Given this list of marker genes Fmr1, Cdyl2, Anp32b, Sf3b4, Pcbp2, Ednrb, Tspan14, Cavin1, Ybx1 (Y box protein 1), Ier2, Junb, Rpl39, Rplp0, Eif3f, Ube2q1, Rnd1, Cdc37, Prdx1, Sdhc, Rpsa, Pkm, Dcn, Klf13, Eed, Mef2c, Eif5a, Set, Rps9, Rps16, Ehd4, Rpl14, Kcnb1, Fnip1, Per2, Dnm3, Cpa1, Selenok, Zkscan1, Cdk13, 1110038F14Rik, Zg16, Cd63, Rpl8, Anxa3, Senp6, Rpl6, Zfp955b, Rps10, Ppp1r9b, Morf4l1, Jund, Rpl4, Rdx, Cela2a, Drap1, Rps17, Psmc1, Nsun4, Cetn2, Smim14, Smagp, Dlgap4 (NCBI Gene Id 98882), Pebp1, Ifitm2, Rbm26, Bri3, Arf4, Rpl36, Fus (NCBI Gene Id 338527), Hlf, Bsg, Slc30a9, Egr1, Tbkbp1, Rapgef4, Csf1r, Nfib, Rps3, Lmcd1, Ttc28, Myct1 (NCBI Gene Id 68632, myc target 1), Tnfrsf1a, Pmm2, 2200002D01Rik, Cebpg, Rnaset2b, Tff2, Taldo1, Sub1, Cic, Csf1, Nop53, Plekho1, Klf7, Tle5, Dusp1, Ext2, Sod1, Selenow, Map1lc3a (microtubule-associated protein 1 light chain 3 alpha), Ginm1, Ptms, Abi1, Rps3a1, Arpc2, Tsc22d1, Pi15, Sfswap, Rhoj, Psmd7, Cox7c, Rpl10a (ribosomal protein L10A), Ppp4c, Zfand5, Adrm1, Selenom, Taok2, Pmp22, Hspb7, Vcf1, Laptm4a (lysosomal-associated protein transmembrane 4A), Sarnp, Rps27a, Rpl24, Sycn, Arl8a, Chid1, Plscr2, Ube2m, Anapc1, Nxn (NCBI Gene Id 18230), Mgll, Smco4, Nbeal1, Tspan17, Rpl27 (ribosomal protein L27), Lsm2, Gabarapl2, Dnaja1, Tpm3, Srpk2, Zfand6, Ncor1, Stard3, Nkx2-3, Scn1b, Picalm, Osbpl8, Nr4a1, Stx4a, Phf20l1, Gnb1, Skil, Ywhae, Ube2v1, Rarg, Magi3, Hmg20b (high mobility group 20B), Hes1, Pa2g4, Rps7, Rpl22, Ftl1, Rbms1 (RNA binding motif, single stranded interacting protein 1), Rnase1, Ccdc85b, 2610005L07Rik, Clta, Ubxn4, Man2c1, Snrnp70, Styx, Abhd8, Rpl3, Bicc1, Ccn1, Tra2a, Map3k6, Ica1, Naxd, Rps27, Hdac7 (histone deacetylase 7), Pfdn5, Sox18, Rps14, Taf7, Ilkap, Trio (triple functional domain (PTPRF interacting)), Tmem204, Prkab1, Ier3, Rpl13, Lrrc8a, Phf21a, Snrpc, Shisa5, Rps4x, Ppp1r35, Ushbp1, Marcks, Rpl9, Tnxb, Syf2, Nbl1, Glt28d2, Dusp3, Col13a1, Pfn1, Pakap, Rplp2, Ubb-ps, Gabarapl1, Thap2, Tex261, Efnb2, Map3k2 (NCBI Gene Id 320245), P2ry12, Hdac10, Cfl1, Rab14, Rpl38, Pla2g1b, Tbca, Abi3, Plekhm2, Zdhhc20, Ubald1, Tamalin, Thap3, Rheb, Abcc5, Kdm6b, Oaz2, Rpl31, H3f3b, Gstm1, Hdac1, Uba52, Htt, Rpl11, Adgrl2, Atp6v1e1 (ATPase, H+ transporting, lysosomal V1 subunit E1), Polr3f, Atf4, Trak2, Dnajc8, Dpysl2, Cbfa2t3, Ctrl, Cd151, Rab22a, Hnrnpa0, Ctsl, Rps8, Srsf5, Ube3a, Zfp36, Ptma, Rps6, Ptdss1, Ccdc9b, Mall, Rpl13a, Arpc4, Oaz1, Col6a2, Zmym4, Abhd17a, Rpl18a, Gga1, Acvrl1 (activin A receptor, type II-like 1), Cdc42ep3, Sertad2, Dync1i2 (dynein cytoplasmic 1 intermediate chain 2), Reep5, Rpl5, Tpt1, Rab5c, Rhoc, Rpl37, Gna11, Gdi1, Tmsb10, Ilk, Arhgdia, Pnrc1, Tomm6, Ppic, Tmem263, Ube2j2, Meox1, Sumo2, Dbp, here is a description of the gene set: Mouse Gene Set: TABULA_MURIS_SENIS_PANCREAS_ENDOTHELIAL_CELL_AGEING species: Mus musculus from publication Tabula Muris Consortium (PMID 32669714)